The following is a description of a gene set: The chemical reactions and pathways involving propionate, the anion derived from propionic (propanoic) acid, a carboxylic acid important in the energy metabolism of ruminants. studied in species Mus musculus Mouse Gene Set: GOBP_PROPIONATE_METABOLIC_PROCESS, and this is the list of marker genes: Pck2, Mmut, Pck1, Acss2, Acss1